Given this list of marker genes Tsc1, Baiap2, Cdc42ep3, Gsn, Asap3, Pxn, Prkn, Lpar1, Pecam1, Washc5, Wdr1, Rdx, Washc4, Cdc42ep2, Cit (NCBI Gene Id 320895), Gpr65, Arhgap28, Capza1, Rnh1, Braf, Arhgef15, Mtpn, Spta1, Coro1b, Pfn2, Gmfg, Nck2, Ptger4, Prkcd (protein kinase C, delta), Rhoc, Ppm1e, Cdc42ep1, Capza3, Itgb1bp1 (NCBI Gene Id 16413), Ccl26, Gba2, Phldb2, Arhgef18, Ppm1f, Pik3ca, Wasf1, Actg1, Cotl1, Avil, Evl, Rhpn2, Pfn1, Add2, Washc3, Fermt2, Fchsd2, Brk1, Tac1, Tgfbr1, Nrp1, Kank3, Nphs1, Actn2, Lima1, Rgs4, Cgnl1, Rasa1, Plekhg2, Cyfip1, Pdxp, Coro1a, Vasp, Wnt4, Grb2, Kank2, Cracd, Wmp, Was, Dlg1, Alms1 (NCBI Gene Id 381791), Cdc42ep4, Lmod1, Myh9, Limk1, Dbn1, Clec2i (C-type lectin domain family 2, member i), Tmod3, Capn1, Prex1, Fhod1, Sorbs3, Cd47, Smad3, Pycard, Arpc5, Dmtn, Capzb, Capza2, Lmod2, Mkks, Apoa1, Kank1, Nckap1, Cyfip2, Shroom2, Twf2, Add1, Myoc, Pak3, S100a10, Ccl11, Sema5a, Gm14137, Mtor, Rictor, Pak2, Dstn, Arhgap18, Vil1, Cx3cl1, Arpin, F2rl1, Cdc42, Capza1b, Icam1, Limch1, Abi2, Kirrel1, Wnt11, Baiap2l1 (NCBI Gene Id 66898), Frmd7, Nox4, Sh3bp1, Washc1, Rhoa, Snx9, Cyria, Abl1, Arfgef1, Naa80, Plek, Arpc5l, Myo1c, Pfn5, C9orf72, Ccn2, Arfip2, Swap70, Ttc8, Plekhh2, Tmsb4x, Inpp5k, Cttn, Carmil2, Slit2, Lmod3, Ccl21e, Tgfb3, Pick1 (NCBI Gene Id 18693), Flii, Sh3pxd2b, Wasf2, Nf2, Mtss1, Gmfb, Gja1, F11r, Ppfia1, Trim27, Rgcc (NCBI Gene Id 66214), Arfip1 (ADP-ribosylation factor interacting protein 1), Abitram, Clasp1, Cdc42ep5, Arhgef10, Ccl21a, Bbs4, Arhgef10l, Arf6, Carmil1, Whamm, Arpc2, Arhgap6, Fmn1, Wasf3, Gm28729, Sptbn1, Prkcq, Bag4, Stmn1, Xirp2, Tlr2, Hax1, Map3k1, Cfl1 (NCBI Gene Id 12631), Met, Shank3, Carmil3, Synpo, Arhgef5, Tmsb15b2 (NCBI Gene Id 100034363), Fer, Prkce, Ptk2b, Epha1, Arhgap35, Serpinf2, Tacr1, Mlst8, Rhpn1, Dlc1, Tjp1, Myadm, Ctnna2, Sptan1, Eps8, Ccl24, Tacstd2, Arap1, Baiap2l2, Bin1, Tesk1, Pak1, Cfl2, Tmod1, Hcls1, Pdlim4, Daam2, Arhgap40, Arpc3, Dnai3, Inppl1, Kiss1r, Scin, Sptb, Pik3r1, Alox15, Tenm1, Ssh3 (NCBI Gene Id 245857), Ssh1, S1pr1, Ppp1r9a, Actr3, Dbnl, Clasp2, Pik3r2, Hip1r, Magel2, Tmod4, Shank1, Kank4, Pfn3, Washc2 (WASH complex subunit 2), Tmeff2, Eln, Lats1, Flna, Fchsd1, Ccl21b, Coro2b, Twf1 (twinfilin actin binding protein 1), Specc1l, Rac1, Tmod2, Fhod3, Tmsb15l, Synpo2, Synpo2l, Nck1, Ccdc88a, Rock2, Rapgef3, Cyrib, Ccl21f, Svil, Capg, Arf1, Vill, Ap1ar, Csf3, Sdc4, Nckap1l, Tpm1, Id1, Esam, Ccl21d, Ssh2, Add3, here is a description of the gene set: Any process that modulates the frequency, rate or extent of actin filament organization. Mouse Gene Set: GOBP_REGULATION_OF_ACTIN_FILAMENT_ORGANIZATION studied in species Mus musculus